Given this list of marker genes CD244, IQCF1, PLA2G4B, SGCB, CCND1, EDARADD, SLC20A1, CCR5, KLHL7, POGLUT1, TIMMDC1, MPP7, RAB32, AHCYL2, SH3RF1, PIK3AP1, ZFP14, MAFF, CEP15, COQ4, CTSE (cathepsin E), IL12A, SHFL, EHD3, PJA1, ELOVL6, RNF157 (NCBI Gene Id 114804), CRYGN, GH1, JADE1, ST6GALNAC2, THOC1, CDHR2, TXNDC15, CDC23, KLHL14, MAF, KY, PAIP1, SNED1, ADAT2, DOCK7, SLC5A9, XAF1, ACP3, KANSL1L, BLOC1S2, CNRIP1, SBSPON, ISOC1, LSM12, ZC4H2, WASF2, RCAN1, PCDH11X, SEC23IP, TMOD4, HGSNAT, PRELID2, GAK, NOTCH2, FAM32A, PI4KB, SMG1, here is a description of the gene set: Human Gene Set: BREDEMEYER_RAG_SIGNALING_NOT_VIA_ATM_UP DNA double-strand breaks are generated by genotoxic agents and by cellular endonucleases as intermediates of several important physiological processes. The cellular response to genotoxic DNA breaks includes the activation of transcriptional programs known primarily to regulate cell-cycle checkpoints and cell survival. DNA double-strand breaks are generated in all developing lymphocytes during the assembly of antigen receptor genes, a process that is essential for normal lymphocyte development. Here we show that in murine lymphocytes these physiological DNA breaks activate a broad transcriptional program. This program transcends the canonical DNA double-strand break response and includes many genes that regulate diverse cellular processes important for lymphocyte development. Moreover, the expression of several of these genes is regulated similarly in response to genotoxic DNA damage. Thus, physiological DNA double-strand breaks provide cues that can regulate cell-type-specific processes not directly involved in maintaining the integrity of the genome, and genotoxic DNA breaks could disrupt normal cellular functions by corrupting these processes. species: Mus musculus from publication Bredemeyer AL, Helmink BA, Innes CL, Calderon B, McGinnis LM, Mahowald GK, Gapud EJ, Walker LM, Collins JB, Weaver BK, Mandik-Nayak L, Schreiber RD, Allen PM, May MJ, Paules RS, Bassing CH, Sleckman BP (PMID 18849970) Genes up-regulated in pre B lymphocyte after induction of physiological DNA double-strand breaks (DSB) by RAG2; the changes are independent of ATM signaling.